The following is a description of a gene set: from publication Chen Y, Wang X (PMID 31504780) studied in species Homo sapiens Genes predicted to be targets of miRBase v22 microRNA hsa-miR-432-3p in miRDB v6.0 with MirTarget v4 prediction scores > 80 (high confidence targets). Human Gene Set: MIR432_3P, and this is the list of marker genes: MTDH, PEG3, LARS1, KRTDAP, ATL2, ESR1, BEAN1, SP1, SMURF1, C1orf43 (NCBI Gene Id 91192), RNF217, PCGF3, FSHB, PLBD2, ILDR2, RNF157 (ring finger protein 157), CNDP1 (carnosine dipeptidase 1), VWA8, YPEL2, HECW1, SH3TC2, HTR4, BMP7, TM9SF3, CFAP107, MBNL3, GSG1L, ERBB4, RSPO1, DRP2, SHISA5, GPM6A, XKR4 (XK related 4), CDH6, OSBPL3, ADAM12, SH3KBP1, SFR1, ZDHHC18, FAM169BP, LYST, ZBTB20, PDK3, GTF2I, HECW2, HLA-DMB, ASZ1, CEP85, STK32C, SYT2, UBR1, HOXD10, PXN, GSE1, ACTBL2, NPAT, GABRR2, YPEL5, SYTL5, CAPZA1, PCLO (piccolo presynaptic cytomatrix protein), SNX3, RBFA (ribosome binding factor A), LAMC2, DYNLL1